Given this list of marker genes CIDEC (NCBI Gene Id 63924), CIDEA, HSD17B13, FITM1, HILPDA (hypoxia inducible lipid droplet associated), FITM2 (fat storage inducing transmembrane protein 2), here is a description of the gene set: Lipid droplets (LDs) are cytosolic structures found in cells of all eukaryotes, comprising a monolayer of phospholipids surrounding a core of uncharged lipids such as triglyceride (TAG) and sterol esters. CIDEA, CIDEB and CIDEC were first studied for their roles in promotion of apoptosis but they are also known to play a role in energy metabolism. CIDEA and C bind to lipid droplets and regulate their enlargement, thereby restricting lipolysis and favouring storage (by promoting net neutral lipid transfer from smaller to larger lipid droplets) (Gao & Goodman 2015). LD formation involves the partitioning of neutral lipids from their site of synthesis at the endoplasmic reticulum (ER) to the cytosol. The fat storage-inducing transmembrane proteins 1 and 2 (FITM1 and FITM2), associated with the ER membrane, mediate binding and partitioning of TAGs into LDs. The short-chain dehydrogenases/reductases (SDR) family is a large family of NAD- or NADP-dependent oxidoreductase enzymes. 17-beta-hydroxysteroid dehydrogenase 13 (HSD17B13) is a recently-discovered enzyme of unknown physiological function that is associated with lipid droplets and significantly upregulated in patients with nonalcoholic fatty liver disease. Hypoxia-inducible lipid droplet-associated protein (HILPDA) is a lipid droplet protein and stimulates intracellular lipid accumulation. species: Homo sapiens part of: Metabolism of lipids Reactome Pathway: Lipid particle organization